The following is a description of a gene set: studied in species Homo sapiens Abnormal femoral neck/head morphology Human Gene Set: HP_ABNORMAL_FEMORAL_NECK_HEAD_MORPHOLOGY, and this is the list of marker genes: GJB2, SMARCAL1, NGLY1, EFL1, RAD21, CBFB, COG1, RBM8A, B3GALT6, NKX3-2, RPS6KA3, WNK3, SRCAP, MMP9 (matrix metallopeptidase 9), KIF22, FAH, COL9A1, ERCC6, PCYT1A, PDE4D, NANS, PLOD3, TMEM67, STXBP1, RAB33B, PHLDB1, UFC1, RTL1, SERPINF1, OTUD5, TCIRG1, RET, GLI3, EXT2, CFAP410, GTF2E2, NRCAM, RINT1, IFIH1, BGN, HSPG2 (heparan sulfate proteoglycan 2), SIL1, RAB23, SLC10A7, ABCC9, ORC1, BRF1, SLC26A2, EIF2AK3, DVL3, FZD2, ARCN1, UNC45A, CRTAP, CTC1, CCN6, MEGF8, DLK1, COL1A2, COL10A1, LHX3, TRIP11, MEG3, DMP1, KCNJ8 (potassium inwardly rectifying channel subfamily J member 8), RSPRY1, COL27A1, EXT1, DYM, UFSP2, PROP1, MMP13, ZMPSTE24, MAN2B1, HNRNPR, COL2A1, UBE3C, BMPR1B, CREBBP, RMRP, SLC12A2, COL9A2, GJB6, NEK9, ATRX, TRAPPC2, ACVR1, SRP54, LMX1B (LIM homeobox transcription factor 1 beta), ADAMTS2, SHOX, CHST3 (carbohydrate sulfotransferase 3), CANT1, SLC35B2, TRPS1, B4GALT7, EP300, HNRNPK, DDRGK1, GNPTAB, CSGALNACT1, TSHB, LHX4, SLC39A13, CHD4, IFT140, PCNT, HSPA9, EZH2, ARID1B, TTI1, MGAT2, TSHR, TG, NFIX, IDUA, AIFM1, FLNA, COL1A1, ATP6V0A2, SLC4A10, KDELR2 (NCBI Gene Id 11014), COMP, ORC6, TONSL (NCBI Gene Id 4796), ENPP1, EED, PTH1R, SKIC3, DUOXA2, RAB3GAP2, ARSL, MATN3, ADAMTSL2, BMP4, COL11A2, TREX1, ACAN, TMEM53, FN1, BCR, RPL13, COG8, SLC35A2, TPO, EXTL3, MTX2, CSPP1, COL9A3, IFNGR1, IYD (NCBI Gene Id 389434), HNRNPH1, PEX5, GALNS, TRAF3IP1, TBX4, IHH (NCBI Gene Id 50819), EXOC6B, MAPK1, PRG4, ATP7A, COL11A1, TRPV4, CDC6, LBR, RNU4ATAC, FUCA1, DVL1, SLC5A5, POP1, LMNA, LRP5, GNPNAT1, CCDC47, PIK3C2A, AFF3, DUOX2, TOMM7, GLB1, SBDS, MBTPS1, WNT5A, XYLT1, FGFR3, TGFB1, PRKAR1A (protein kinase cAMP-dependent type I regulatory subunit alpha), SLC2A10, POC1A, RUNX2, FKBP10, COG4, FLNB, CRKL, TGFB3, TINF2, HESX1, GNPTG, LYSET, POU1F1, KIAA0586, HS2ST1, DNAJC21